The following is a description of a gene set: species: Mus musculus Catalysis of the reaction: L-lysyl- + NAD+ = H+ + N(6)-(ADP-D-ribosyl)-L-lysyl- + nicotinamide. Mouse Gene Set: GOMF_NADPLUS_PROTEIN_LYSINE_ADP_RIBOSYLTRANSFERASE_ACTIVITY, and this is the list of marker genes: Parp10, Parp3, Sirt6, Parp16, Parp11